Given this list of marker genes HAAO, IDO1, ACMSD, KMO, KYNU (NCBI Gene Id 8942), QPRT, here is a description of the gene set: The chemical reactions and pathways involving quinolinate, the anion of quinolinic acid, also known as 2,3-pyridinedicarboxylic acid. Human Gene Set: GOBP_QUINOLINATE_METABOLIC_PROCESS studied in species Homo sapiens